Given this list of marker genes HYCC2, MYO1D, FAT4, KLF3, PHIP, XYLT1, NCOA3, ABHD10, NELL2, ZNF471, CBFA2T3, STBD1, STRIP2, PHF3, FLNB, FOXO1, PWWP3B, SCN8A, TEAD1, TMEM62, CEP20, POLH, ENPP5, TNPO1, GALNT3, PLSCR5, ARF6, SDK1, TNFAIP8L3, FMN1, TUT4, TIMP2, PUM3, TENM4, HTR3D, ZNF853, DCP1A, GAN, ZNF518A, LTN1, TDRP, LACTB, NOD1, SLC22A1, RNF214, KRT6A, TSC22D2, DARS2, FBRSL1, PALD1, PPP2R3A, PAK5, MSANTD2, PARPBP (NCBI Gene Id 55010), RAB37, APPBP2, IKZF2 (NCBI Gene Id 51173), AAK1, USP12, TBCK, BMPR2 (bone morphogenetic protein receptor type 2), POLR3E, DNAJC1, SLC39A10, GTF2A2, MED13L, CDR2, CASP7, WARS2, ASTN1, SRSF2, TMEM167A, XIRP2, BRMS1L (NCBI Gene Id 84312), TOX, STMN2, PERP, TMEM67, WDR1, VCPIP1, ETV5, EBF2, NAPB, MTMR12, NUFIP2, PLPPR4, SDHD, AMER2, SEPTIN9, ZNF704, MAP3K1, COL5A1, KBTBD4, LYRM2, CTTNBP2NL, ZNF737, NIPBL, HMGA2, C17orf67, TBL1X, DNM1L, AEBP2, NFIB, GLTP, DENND10, VEGFD, ABI1, CACNB4, VAMP4, PDCD6IP, GPATCH2L, GUCY2C, NCAM2, USP9X (ubiquitin specific peptidase 9 X-linked), OSBPL8, COMMD2 (COMM domain containing 2), SOCS7, CCL13, CTDP1, PCLO, DUSP26, KIF13A, RET, WDFY3, NWD1, CLCF1, LYST, SAMD4A, TSHR, FLRT1, KDM3A, DARS1, SMAD4, ZBTB34, KALRN, CNTN3, RASSF10, PPM1A, CSDE1, TPM1, BNC1, IPO5, LPAR1, SREK1IP1, C6orf62, ATP2A2, PLK2, MRPS30, POU3F2, CHURC1, AKAP5, USP8, SUSD6, UBE2L3, ZNF695, RAD51D, DCP2, SERPINA9, GTPBP10, SACS (NCBI Gene Id 26278), SLC5A3, ZNF236, ABCD3, MAP2, HERPUD1 (NCBI Gene Id 9709), SESN3, SPRY1, COL19A1, SLC25A22, ENAH, MYORG, CDKN2AIP, AZIN1, CRIM1, ARHGAP20, KCNJ3, ORC4, RAP2A, C14orf132, SLC41A2 (solute carrier family 41 member 2), ADGRL3, TMEM260, RAP1GAP2, FUT9, RAP2C, RELN, BIRC6 (baculoviral IAP repeat containing 6), NKX6-2, DDX5, TMED5, ATP6V1D, CEACAM7, PNISR, CDH1, MIS18BP1, DUSP2, POLR1E, SAR1A, SLC10A2, HGF, SYNPO2, NUFIP1, ARRDC4, PAX9, CYP19A1, FAM98A, NARS2, POLR3G, ATP11A (ATPase phospholipid transporting 11A), HTATSF1, PI4K2A, CISD2, GTF2H1, PLEKHG1, TTC14, NIPA2, SLC35G2, ZNF234, TGFBR2, here is a description of the gene set: Genes predicted to be targets of miRBase v22 microRNA hsa-miR-544a in miRDB v6.0 with MirTarget v4 prediction scores > 80 (high confidence targets). from publication Chen Y, Wang X (PMID 31504780) species: Homo sapiens Human Gene Set: MIR544A